The following is a description of a gene set: Mouse Gene Set: GOBP_SPINDLE_ELONGATION species: Mus musculus The cell cycle process in which the distance is lengthened between poles of the spindle., and this is the list of marker genes: Aurkb, Kif4, Racgap1, Kif11, Prc1, Birc5, Cdca8, Incenp (inner centromere protein), Ppp2r1a, Numa1, Map10, Kif23